Given this list of marker genes Star, Lcn2, Cyp1a1, Th, Htra2, Alad, here is a description of the gene set: studied in species Mus musculus Mouse Gene Set: GOBP_RESPONSE_TO_HERBICIDE Any process that results in a change in state or activity of a cell or an organism (in terms of movement, secretion, enzyme production, gene expression, etc.) as a result of a herbicide stimulus. Herbicides are chemicals used to kill or control the growth of plants.